Given this list of marker genes CD55, SERPING1, CR2, A2M, CR1, CD59, SUSD4, CR1L, C4BPA, VSIG4, C4BPB, CD46, MASP1, here is a description of the gene set: Any process that stops, prevents, or reduces the frequency, rate or extent of complement activation. species: Homo sapiens Human Gene Set: GOBP_NEGATIVE_REGULATION_OF_COMPLEMENT_ACTIVATION